The following is a description of a gene set: Decreased width of the bony bridge of the nose. studied in species Homo sapiens Human Gene Set: HP_NARROW_NASAL_BRIDGE Narrow nasal bridge, and this is the list of marker genes: KCNJ6, MDM2, SMARCA4, RECQL4, PPP1R21, MAGEL2, SHH, RNF13, MED12, MMP2, PAX3, KCNK9, DISP1, NDP, GDF5, CREBBP (CREB binding protein), CRIPTO, RNU4ATAC, SMARCA2, COL3A1, SNORD116-1, PWRN1, COG4, SRCAP, HERC2, NPAP1, NFIB, DLL1, SUFU, FGF8, FGFR1, ZIC2, CDON, SNORD115-1, GLI2, SIX3, SIM1, PWAR1, BMPR1B, HNRNPR, PORCN, NONO, NODAL, FOXH1, MKRN3 (makorin ring finger protein 3), GJA1, TGIF1, SNRPN, GAS1, PTCH1, EP300